The following is a description of a gene set: Mouse Gene Set: GOBP_NEUROTROPHIN_TRK_RECEPTOR_SIGNALING_PATHWAY The series of molecular signals initiated by neurotrophin binding to its receptor on the surface of a target cell where the receptor possesses tyrosine kinase activity, and ending with the regulation of a downstream cellular process, e.g. transcription. studied in species Mus musculus, and this is the list of marker genes: Slc9a6, Bcar1, Ndn, Spry2, Ptpn11, Sort1, Tmem108, Lmtk2, Ulk1 (NCBI Gene Id 22241), Ptprf, Wasf1, Zfyve27, Ntrk1, Akt1s1, Zdhhc17, Cd2ap, Cyfip2, Hap1, Sos1, Ppp2r5b, Casp3, Src, Ddit4, Spry1, Sh3glb1, Bex1, Raf1, Ngf, Agt, Ppp2r5d, Agtr2, Cyfip1, Dok5